The following is a description of a gene set: Human Gene Set: GOMF_EPHRIN_RECEPTOR_ACTIVITY Combining with an ephrin receptor ligand to initiate a change in cell activity. species: Homo sapiens, and this is the list of marker genes: EPHA6, EPHA7, EPHA1, EPHB1, EPHB3, EPHA4, EFNA3, EFNB3, EPHA10, EPHA2, EPHB2, EFNA4, EPHA5, NTRK1, EPHB4, EPHA3, EPHA8, NTRK3, EPHB6